The following is a description of a gene set: Thymic-derived natural T regulatory cells (nTregs) are characterized by functional and phenotypic heterogeneity. Recently, a small fraction of peripheral Tregs have been shown to express Klrg1, but it remains unclear the extent Klrg1 defines a unique Treg subset. Here we show that Klrg1+ Tregs represent a terminally differentiated Treg subset derived from Klrg1- Tregs. This subset is a recent antigen-responsive and a highly activated short-lived Treg population that expresses enhanced levels of Treg suppressive molecules and that preferentially resides within mucosal tissues. The development of Klrg1+ Tregs also requires extensive IL-2R signaling. This activity represents a distinct function for IL-2, independent from its contribution to Treg homeostasis and competitive fitness. These and other properties are analogous to terminally differentiated short-lived CD8+ T effector cells. Our findings suggest that an important pathway driving antigen-activated conventional T lymphocytes also operates for Tregs. Gene expression analysis was performed of this and other Treg subsets based on expression of CD62L, CD69, and Klrg1 to define the molecular properties of Klrg1+ Tregs and its relationship to other Treg subsets found in the peripheral immune tissues. Human Gene Set: GSE36527_CD62L_HIGH_VS_CD62L_LOW_TREG_CD69_NEG_KLRG1_NEG_UP Genes up-regulated in CD69- KRLG1- T reg: SELL high versus SELL low. species: Homo sapiens from publication Cheng G, Yuan X, Tsai MS, Podack ER, Yu A, Malek TR (PMID 22786769), and this is the list of marker genes: PARP9, IL18RAP, RAB10, CD274, SEMA7A, TOR1AIP2, PSIP1, ISOC1, IRF9, HIF1A, LARP1, STK32B, ISG15, ARNT, RFC5, WIPF1, IFIT3, OASL, TRIM34, C5orf47, UHRF1 (ubiquitin like with PHD and ring finger domains 1), SLC12A6, RUNX2, GRIK1, AIDA, USP18, CMTR1, GRK6, SLC46A2, NCKAP1, ATL3, PNPLA2, USP36, IST1, ADSS1, SH3BP2, USO1, SREBF1, ANKRD6, MX2, LIG3, ANKRD46, ZNF280C, CLIP2, RPL3, TOPBP1, PIDD1, NIN, PARP12, BLTP3B, RTP4, BMI1, GOLGA7, HLA-E, FGF23, SP110, PIK3C3, HELZ2, TOR3A, HTRA1, FGL2, ITSN2, RPL6, PEX26, CLIC4, TRIM25, CD200R1, DAXX, PARP14, WDR36, MAU2, OTUD5, BLTP2, UBR7, LAMP2, SMC1A, IRF1, NUDT4, RESF1, TRIM21, WDR46, ETFA, GPM6B, DLD, DKK2, MOV10 (NCBI Gene Id 57723), GZMB (NCBI Gene Id 3002), CD164, CMTM6, RFFL, YWHAZ, TNNT2, CAPN8, SOCS3, HUWE1, ARF1, WDR43, TMBIM6 (NCBI Gene Id 7009), MAP3K8, OSBPL5, ASB13, ARL1, RGN, PI4K2A, STAG2, PIM2, UBE2I, B4GALT5, LIF, TTC39B, EEFSEC, TAPBP, FNBP4, BIRC2, SLFN13, HOPX, CXCL10, IRF7, OAS2, OTULIN, RBM43, MITF, FXR1, SLC41A1, STRAP, RHOH, ZNFX1, TNFRSF1B, ITGA4, SHISA5, CASP2, CLPTM1L (CLPTM1 like), SPTBN1, FAS, TRIM31, N4BP1, SUCLG2, PUS10, NRIP2, FAM133B, ARL6IP1, TRAFD1 (TRAF-type zinc finger domain containing 1), ATP2A2, HSPA5, RNF114, TAP1, ST6GALNAC4, CLVS1, IBTK, SSB, UIMC1, GLA, CHCHD6 (coiled-coil-helix-coiled-coil-helix domain containing 6), CRLF3, PRPS1, CHD1, HLA-DOB, KCNA3 (potassium voltage-gated channel subfamily A member 3), FAM241B, NUP153, IGSF9, STAT1, RBPJ, DHX58, APAF1, RAD51AP1, POLD3, TTC27, B3GNT2, CYSLTR2, ZNF639, RAB27A, CD3E, PML, DCAKD (NCBI Gene Id 79877), IL10RA, DDX24, IFIT2, SLC15A3, IFIT1B, CCNL2, NKAP (NFKB activating protein), PITX2, IRGM, CRYBG1, AFMID, EVI2B, STAT2, TRIM26, PPP2R2A, TBX4, F13A1, CHMP4B, SRGAP3, SERPINB9, MXD1, TREX1, STK24, MACIR, CH25H